Given this list of marker genes Aard, Nr3c2, Scn11a, Gnai1 (NCBI Gene Id 14677), Src, Mstn, Adh1, Slc39a9, Cad, Cybb, Nefl, Prkaa1, Nqo1, Nkx2-2, Cdc5lrt6, Wbp2 (NCBI Gene Id 22378), Lipa, Inhba, Fosl1, Postn, Htr7, Mir155, Ccl19-ps5, Rock2, Cav1, Fgf2, Prkce, Hdac6, Ddit4, Ucp3, Stk39, Slc12a3, Ucp1, Gabrb1, Card9, Ep300, Psph, Agtr2, Tgfb2, Rwdd1, Ptger2 (NCBI Gene Id 19217), Spp1, Agtr1a, Bglap2, Yap1, Akap8, Fech, Bglap3, Ifnb1 (NCBI Gene Id 15977), Mbp, Hnrnpk, Maob, Ar, F5, Cps1, Oxtr (NCBI Gene Id 18430), Axin2, Srd5a2, Scnn1a, P2ry6, Rpl27, Ucp2, Sin3a, A2m, Tbxa2r, Hnrnpu, Sphk2, Egfr, Epo, Uts2, Slit3, Gba1, Nkx3-1, Ccl19-ps6, Fdx1, Asns, Hnrnpd, Bcl2l1, Tyms, Ccl21d, Trim63, Star, Acod1, Ccl19-ps1, Csn1s1, Pik3ca, Hpca, Hoxa9, Cdc5lrt10, Acaca, Agtr1b, Comt, Aanat, Ptger4, Gnas, Cyp27b1, Map4k1, Tspo (translocator protein), Creb1, Pck1, Sfrp1, Akr1b1, Elk1, Glb1, Fbp1, Msn, Tacr1, Abcb1a, Foxo1, Efna5, F7 (coagulation factor VII), Bmi1, Por, Rnf4, Eif4e, Ass1, Jak2, Cdc5l, Avpr1a, P2ry4, Ccl19-ps4, Adcy1, Mir21a, Akr1c18, Tat, Fosb, Gjb2, Ptgfr, Prkaa2, Hrh3, Slco1a1, Cacna1b, Adcy8, Plcg1, Foxo3, Defb1, Ifitm5, Tgfb1, Cyp1a1, Tnfsf4, Errfi1, Gas6, Ucn3, Ugt3a1, Aqp1, Kcnj11, Cldn1, Trerf1, Ccl2, Prkd1, Cflar, Ccl21a, Ccl21e, Pcna, Klf4, Abcb4, Klf9, Ccl21b, Vps54, Cda, Rps6kb1, Golph3, Scnn1g, Hnf1a, Cbl, Pappa, Pck2, Csnk2a1, Ahr, Aifm1, Nr1h3, Pax6, Eif4ebp1, Abcc2, Gdnf, Tgfb3, Ppp1r9b, Cyp1b1, Cd38, Gad2, Npas4, Sgk1, Cdc5lrt4, Gkn2, Cdc5lrt5, Ccl21f, Ccl19-ps3, Hspa8, Borcs7, Park7, Hoxb13 (homeobox B13), Hsf1, Adam15, Trh, Adcy6, Klf2, Ptger3, Pf4, Ugt3a2, Scnn1b, Cdc5lrt8, Bglap, Akt1, Slc5a5, Edn1, Adcy5, Cdc5lrt9, Hoxa10, Tbx2, Bmp4, Sox10, Ptgdr, Ncoa2, Txnip, Serpinf1, Cdc5lrt7, Mup11, Car9, Cldn4, Ccl19, Arpc2, Ace, Ghsr, Ptafr, Fbxo32, Fos, Pln, Tnc, Atp5f1a, Crh, Ccr7, Hmgcs2, Mup1, Gpi1, Abhd2, Tgfbr3, Cdk4, Cftr, Cdc5lrt1, Cdkn1a, Ptger1, Larp1, Esr2, Hdac8, Oxt, Nanog, Calr, Hoxa11, Th, Sirt1, Ncoa1, Avp, Srebf1, Foxp3, Rela, Hoxd13, Mettl21c, Adcy3, Btg2, Grip1, Epha5, Casp9, Dsg2, Ube3a, Hoxa13, Nr3c1, Adcy2, Rplp0, Smyd3, Ghr, here is a description of the gene set: studied in species Mus musculus Mouse Gene Set: GOBP_RESPONSE_TO_KETONE A response that results in a state of tolerance to ketone.